The following is a description of a gene set: Human Gene Set: HP_ELEVATED_CREATINE_KINASE_AFTER_EXERCISE species: Homo sapiens Elevated creatine kinase after exercise, and this is the list of marker genes: RYR1, AMPD3, AMPD1, ACAD9, ALDOA, CAV3, CACNA1S, ANO5, DPM3, SLC25A20, DNA2, LDHA